The following is a description of a gene set: from publication Baus-Loncar M, Schmid J, Lalani el-N, Rosewell I, Goodlad RA, Stamp GW, Blin N, Kayademir T (PMID 16121031) studied in species Mus musculus BACKGROUND AND AIMS: The gastrointestinal trefoil factor family (TFF1, TFF2, TFF3) peptides are considered to play an important role in maintaining the integrity of the mucosa. The physiological role of TFF2 in the protection of the GI tract was investigated in TFF2 deficiency. METHODS: TFF2-/- mice were generated and differential expression of various genes was assessed by using a mouse expression microarray, quantitative real time PCR, Northern blots or immunohistochemistry. RESULTS: On an mRNA level we found 128 differentially expressed genes. We observed modulation of a number of crucial genes involved in innate and adaptive immunity in the TFF2-/- mice. Expression of proteasomal subunits genes (LMP2, LMP7 and PSMB5) involved in the MHC class I presentation pathway were modulated indicating the formation of immunoproteasomes improving antigen presentation. Expression of one subunit of a transporter (TAP1) responsible for importing degraded antigens into ER was increased, similarly to the BAG2 gene that modulates chaperone activity in ER helping proper loading on MHC class I molecules. Several mouse defensin (cryptdin) genes coding important intestinal microbicidal proteins were up-regulated as a consequence of TFF2 deficiency. Normally moderate expression of TFF3 was highly increased in stomach. Mouse Gene Set: BAUS_TFF2_TARGETS_UP Genes up-regulated in pyloric atrium with knockout of TFF2., and this is the list of marker genes: Ccl8, Dpep1, Guca2b, Igkv4-91, Abcg2, Ifit1, Bcat2, Ltb, Ada, Gnb1, Ighm, Zeb1 (zinc finger E-box binding homeobox 1), Crip1, Ptpn22, Ms4a1, Psmb9, H2-K2, Slc2a2, H2-T13, Tff3, Slfn2, Rbp2, Ggt1, Samhd1, Igkv4-77, Itln1 (NCBI Gene Id 640587), Tap1, Irf7, Zg16, Ogfr, Igtp, Dgka, Apoc2, H2-K1, Cyp2d9, Apoa4, Defa5, Psmb8